Given this list of marker genes FUS, RBM10, SUGP1, LSM3, PCBP1, SNRNP35, PRP4K, PNN, DDX42, SF3B6, PUF60, YBX1, SRSF11, SF3A2, HSPA8, SRRT, HNRNPH2, ZMAT2, SF3B1, RBM25, RBMX2, RBM17, PRPF4, C9orf78, GPKOW, ACIN1, PPP1R8, LSM4, SNRPE, TXNL4A, LENG1 (leukocyte receptor cluster member 1), DHX8, SRSF2, PPIL3, HNRNPC, CASC3, SNRNP200, CDC40, MFAP1, SNRPN, SNRPA1, DDX41, CWF19L2, CWC25, HNRNPA1, PPWD1, U2AF2, DNAJC8, MTREX, SMU1, HNRNPF, RBM42, SNU13, HNRNPU, SNRNP27, IK (NCBI Gene Id 3550), HNRNPA3, CWC22, RBM22, POLR2H, FAM50A, TFIP11, POLR2A, SNRPB2, CWC15, CHERP, DHX9, CACTIN, PRKRIP1, ISY1, SF3B5, PPIE, RBM39, SF3B3, PRPF31, PRCC, ZMAT5, GPATCH1, SRSF10, PRPF3, RBM5, SF3A1, HNRNPA2B1, CRNKL1, HNRNPH1, U2SURP, LSM8, SRSF1, PPIL4, SNIP1, LSM5, SNRNP48, GCFC2, POLR2C, SART1, PDCD7, POLR2G, MAGOHB, RBM7, TRA2B, SRSF9, CDC5L, STEEP1, SRSF3, SNRPG, DDX39B, PRPF8, DDX46, POLR2D, DHX16, SRSF5, PRPF19, CWC27, TCERG1, NSRP1, HTATSF1, USP39, CTNNBL1, RBM8A, SRSF4, AQR, NKAP, RNPS1, GTF2F2, SNRPF, POLR2J (RNA polymerase II subunit J), CCAR1, HNRNPK, U2AF1, PHF5A (PHD finger protein 5A), SMNDC1, EIF4A3, XAB2, SRSF7, PLRG1, SNW1, DHX15, SF3B2, SRRM2, SNRPA, NCBP2, SDE2, SRSF12, NCBP1, LUC7L3, GTF2F1, SNRNP70, SNRPB, SF3B4, ZRSR2, BCAS2, POLR2L, FAM32A, PPIL2, WBP11, PRPF18, PCBP2, BUD13, RNPC3, LSM7 (LSM7 homolog, U6 small nuclear RNA and mRNA degradation associated), PTBP1, SNRPC, SF1, MAGOH, SRSF8, PPIG, SAP18, LSM6, ZCRB1, HNRNPR, DDX23, DHX38, PRPF40A, SNRPD1, PQBP1, DHX35, POLR2K, PPIL1, RBMX, SNRPD2, HNRNPD, POLR2I, SRRM1, EFTUD2, LSM2 (LSM2 homolog, U6 small nuclear RNA and mRNA degradation associated), SLU7, POLR2E, DDX5, WDR70, SNRNP40, PRPF38A, ALYREF, WBP4, HNRNPL, UPF3B (UPF3B regulator of nonsense mediated mRNA decay), POLR2B, U2AF1L4, PRPF6, PPIH, HNRNPM, POLR2F, SF3A3, SNRPD3, RNF113A, SYF2, YJU2, SRSF6, UBL5, SNRNP25 (small nuclear ribonucleoprotein U11/U12 subunit 25), CCDC12, ZNF830 (NCBI Gene Id 91603), BUD31, here is a description of the gene set: Human Gene Set: REACTOME_MRNA_SPLICING mRNA Splicing species: Homo sapiens